The following is a description of a gene set: Mouse Gene Set: GOMF_U1_SNRNP_BINDING Binding to a U1 small nuclear ribonucleoprotein particle. studied in species Mus musculus, and this is the list of marker genes: Snrpa, Snrpd2, Rbm39, Snrpb, Snrpd1, Snrpd3, Snrpc, Snrpg, Snrnp70, Snrpe